Given this list of marker genes ZNF138, SLC35A3, EEF2KMT, SLC39A2, KCNA4, GRIA1, API5, EHMT1, GPR161, UBE2B, MTF2, APLP2, SLTM, RAP2B, ST8SIA1 (ST8 alpha-N-acetyl-neuraminide alpha-2,8-sialyltransferase 1), ZFYVE21, XPR1, COPS8, DOCK3, ZNHIT6 (zinc finger HIT-type containing 6), TMEM45A, CHSY1, NYNRIN, MATR3, ABCC11, KCND2, ZNF714, CAB39, DTD1, RANBP3L, ATAD2B, BIN3, NT5C2, FRMD4B, GPT2, TOP3A, TPM3, QKI, RSL24D1, RPP14, EDN3, EBF4, FBXO45 (NCBI Gene Id 414772), OTUD1, GOLGA7, C7orf25, LPCAT1, POU2F1, CREBL2, METTL9, CCDC43, ZNF28, THSD7B, ITPKB (NCBI Gene Id 3707), TFCP2L1, COL14A1, TMEM164, FAM199X, PHACTR2, TMEM41B, RSBN1, YWHAG, CCDC198, MCCC1, ZNF99, ZNF43, AUTS2, CASP10, ACVR2B, NOVA2, AP3S1, ATP10B, ZNF420, HOXC10, SUDS3, GNA12, ISL1, CDC42EP4 (NCBI Gene Id 91740), ZNF639, LRRC10B, ERCC6, ZNF595, OGFRL1, ITGB8, LPGAT1, ZNF681, LCOR, SEZ6L, ZNF528, ANKRD30A, FRS2, CDH26, ASPH, PLEKHG7, ITGA8, ZNF559, DCLK3, SPEN, MTHFD1L, GNPDA2, CAMKK1, CLCF1, DLGAP5, LTBP1, ZNF92, ZFAND4, PTPRM, LONRF2, FBN3, UBE2H, HIP1R, EEIG2, DUSP3, SLC4A7, P4HA2, COA5 (NCBI Gene Id 493753), NRAS, FURIN, SLC9A2, NDUFAF5, MIB1, VEZF1, ITSN1, BMPR1B, CERT1, NOTCH2, RAB3IP, CLIC6, PIKFYVE, ZNF552, ZNF566, ME1, FSHB, GLIS3, ZNF765, BMS1, VCPIP1, NNT, SMARCD1, CSRNP1, UBASH3B, CREB5, BORA, ELAVL2, TRIM39 (tripartite motif containing 39), WNT3, RGS17, NEK9, SPOPL (NCBI Gene Id 339745), TMEM241, PLAGL2, CCN1, SLC27A6, CREBZF, CHMP3, GNB4, DIXDC1, RAB9A, RASSF3, LPCAT3, PAQR8, PTPRB, ZNF691, TAL2, SLC5A12, ZNF248, UBXN4 (UBX domain protein 4), AJAP1, OSTC, IL6R, DYM, ZNF705A, CEMIP2, RFX8, PDE3B, MADCAM1, NEXMIF, FAM135B, CLNK, NXPE4, ZFYVE28, BAG1, NAV1, SCN8A, AGPAT3, RERE, GTF2E1, PLAAT5, SGCZ, ZFY, GCNT2, SRD5A3, TIPRL, PLCL2, LRRC32, TMPRSS11E, ZBTB10, ZNF773, EPN2, SH3TC2, MAPRE1, TCEA3, IWS1, RMDN2, MLXIP, PUM1, RTF1, BEND7, TNFAIP8L1, TENT4A, PSMC4, FGFR2, NIF3L1, HSPA12A, VKORC1L1, MSTN, RNF144B, ULK2, GLRX, MARCHF6, RBM43, FOXE1, PI15, CSNK1G1, NAF1, NR1D2, CCDC141, PLEKHA1, G3BP2, WIPF2, SEMA3E, NR3C1, C6, POGK (pogo transposable element derived with KRAB domain), TGFBR2, PRR3, ALG9, TENM1, RNF103-CHMP3, ADARB1, HEY2, PAX5, PDGFRA, NPY1R, NAV2 (neuron navigator 2), AFF4, PASK, AFF2, CACNB3, KLF6, GATAD2B, LMOD1, ARPP21, CLOCK, ILDR2, STX6, FUT9, USH2A, LIN7A, KCNH5, ZNF680, CADM2, MPP1, MBNL3, TSC22D1, ZNF365, PPP2R2A, LDHC, ZNF207, UBE2K, CPEB2, SLITRK5, LRRN2, TC2N, UBE2Q2, CDH11, POLR2D, ZCCHC9, CNOT6L, SLC25A5, LRRC28, ARMC1, HS3ST3B1, MARCKS, CCDC186, RAB8A, CACNA1A, ELK4, NFIB, DENND4A, SUMO2, CASP9, SPECC1, BCL9, CDK14, PROX1, BMP8B, ETV1, IL6, PHC3, EBF3, ITPRIP (inositol 1,4,5-trisphosphate receptor interacting protein), CA4, MAGEA11, here is a description of the gene set: species: Homo sapiens Genes predicted to be targets of miRBase v22 microRNA hsa-miR-515-5p in miRDB v6.0 with MirTarget v4 prediction scores > 80 (high confidence targets). from publication Chen Y, Wang X (PMID 31504780) Human Gene Set: MIR515_5P